The following is a description of a gene set: Genes negatively correlated with antibody response in peripheral blood mononuclear cell in young adults (18-25) after exposure to HPV-16 L1 VLP, time point 12M. Comment: Spearman Correlation of Gene Expression with Neutralizing Antibody Levels Human Gene Set: GARCIA_PINERES_PBMC_HPV_16_L1_VLP_AGE_18_25YO_12MO_CORRELATED_WITH_ANTIBODY_RESPONSE_NEGATIVE studied in species Homo sapiens Human papillomavirus (HPV) virus-like particle (VLP) vaccines were recently licensed. Although neutralizing Ab titers are thought to be the main effectors of protection against infection, early predictors of long-term efficacy are not yet defined and a comprehensive understanding of innate and adaptive immune responses to vaccination is still lacking. Here, microarrays were used to compare the gene expression signature in HPV-16 L1 VLP-stimulated PBMCs from 17 vaccine and 4 placebo recipients before vaccination and 1 mo after receiving the second immunization. Vaccination with a monovalent HPV-16 L1 VLP vaccine was associated with modulation of genes involved in the inflammatory/defense response, cytokine, IFN, and cell cycle pathways in VLP-stimulated PBMCs. Additionally, there was up-regulation of probesets associated with cytotoxic (GZMB, TNFSF10) and regulatory (INDO, CTLA4) activities. The strongest correlations with neutralizing Ab titers were found for cyclin D2 (CCND2) and galectin (LGALS2). Twenty-two differentially expressed probesets were selected for confirmation by RT-PCR in an independent sample set. Agreement with microarray data was seen for more than two-thirds of these probesets. Up-regulation of immune/defense response genes by HPV-16 L1 VLP, in particular, IFN-induced genes, was observed in PBMCs collected before vaccination, with many of these genes being further induced following vaccination. In conclusion, we identified important innate and adaptive response-related genes induced by vaccination with HPV-16 L1 VLP. Further studies are needed to identify gene expression signatures of immunogenicity and long-term protection with potential utility in prediction of long-term HPV vaccination outcomes in clinical trials. from publication García-Piñeres AJ, Hildesheim A, Dodd L, Kemp TJ, Yang J, Fullmer B, Harro C, Lowy DR, Lempicki RA, Pinto LA (PMID 19155521), and this is the list of marker genes: SLC43A1, SORL1, CXCL2, ADD3, PLIN2, MZF1, HS3ST1, TNS1 (tensin 1), HPCAL1, SNCA, SPAG8, SRRM2, RBMS2, CHRNA7, FUCA1, HS3ST2, KRT5, CFD, IMPA2, LEF1